The following is a description of a gene set: The deposition of calcium salts in the parenchyma of the renal medulla (innermost part of the kidney). Human Gene Set: HP_MEDULLARY_NEPHROCALCINOSIS Medullary nephrocalcinosis studied in species Homo sapiens, and this is the list of marker genes: CRELD1, IFT56, SLC34A3, CYP24A1, CTNS, ABCC6, INSR, MAGED2, ENPP1, SLC34A1, POLRMT, TOR1A (NCBI Gene Id 1861), ADAT3, FGF23